The following is a description of a gene set: studied in species Homo sapiens Human Gene Set: GOBP_MAMMARY_GLAND_EPITHELIAL_CELL_PROLIFERATION The multiplication or reproduction of mammary gland epithelial cells, resulting in the expansion of a cell population. Mammary gland epithelial cells make up the covering of surfaces of the mammary gland. The mammary gland is a large compound sebaceous gland that in female mammals is modified to secrete milk., and this is the list of marker genes: RREB1, BTRC, TNFSF11, CEBPB, IQGAP3, MED1, CDKN2A, GATA3, ZNF703, GPX1, KDM5B, WNT5A, PHB2, BAX, ROBO1, DEAF1, ID2, STAT6 (NCBI Gene Id 6778), BRCA2, CCND1, PYGO2, EPHA2, ESR1 (estrogen receptor 1), AREG, TFAP2C, RTN4, HOXA5, MAPK1